The following is a description of a gene set: from publication Xie X, Lu J, Kulbokas EJ, Golub TR, Mootha V, Lindblad-Toh K, Lander ES, Kellis M (PMID 15735639) Comprehensive identification of all functional elements encoded in the human genome is a fundamental need in biomedical research. Here, we present a comparative analysis of the human, mouse, rat and dog genomes to create a systematic catalogue of common regulatory motifs in promoters and 3' untranslated regions (3' UTRs). The promoter analysis yields 174 candidate motifs, including most previously known transcription-factor binding sites and 105 new motifs. The 3'-UTR analysis yields 106 motifs likely to be involved in post-transcriptional regulation. Nearly one-half are associated with microRNAs (miRNAs), leading to the discovery of many new miRNA genes and their likely target genes. Our results suggest that previous estimates of the number of human miRNA genes were low, and that miRNAs regulate at least 20% of human genes. The overall results provide a systematic view of gene regulation in the human, which will be refined as additional mammalian genomes become available. species: Homo sapiens Genes having at least one occurrence of the highly conserved motif M121 CCAWWNAAGG in the regions spanning 4 kb centered on their transcription starting sites. This matches the SRF transcription factor binding site V$SRF_Q4 (v7.4 TRANSFAC). Human Gene Set: CCAWWNAAGG_SRF_Q4, and this is the list of marker genes: ACTC1, PICALM, HOXC5, PODN, SRF (serum response factor), NKX2-1, ZNF644, NPM3, PDLIM5, KCTD15, TCF4, DIXDC1, RUNDC1 (NCBI Gene Id 146923), NPPA, ACTB (actin beta), SCOC, VIT, EGR2, ACTG2, NKX6-1, MRGPRF, KCNK3, MAP3K20, SREK1, TAGLN, FLNA, CAVIN2, LINC00311, PCDH7, PRMT3, ATRX, TNNC1, LSP1, SUSD1, PHF12, ERBIN, MBNL1, DAPK3, NKX2-2, RARB, INSM1, SP7 (NCBI Gene Id 121340), UBE2C, CSRP1, TRDN, AARSD1, PRDM1, SCN3B, PLCB3, CFL2, NR4A1, RASSF2, PSENEN, KLF6, PTCH1, THBS1, DUSP5, PPP1R12A, FGFRL1, FOSB, MYLK (NCBI Gene Id 50483), HOXD13, ACTA1, SVIL, U2AF1L4, LIN37, EGR1 (NCBI Gene Id 1958), EPHB1, H3-3A, MAPKAPK2, TPM2, SYT9, PFN1, DUSP2, CKM, ANP32E, HOXD10, TFE3, PLN, MYH11, NPAS2, CALD1, DEFB129, TMEM47, RAB30, MYL7, IRAG1, CORO1C